The following is a description of a gene set: from publication Cui A, Huang T, Li S, Ma A, Pérez JL, Sander C, Keskin DB, Wu CJ, Fraenkel E, Hacohen N (PMID 38057668) Cytokines mediate cell-cell communication in the immune system and represent important therapeutic targets. A myriad of studies have highlighted their central role in immune function, yet we lack a global view of the cellular responses of each immune cell type to each cytokine. To address this gap, the authors created the Immune Dictionary, a compendium of single-cell transcriptomic profiles of more than 17 immune cell types in response to each of 86 cytokines (>1,400 cytokine-cell type combinations) in mouse lymph nodes in vivo. A cytokine-centric view of the dictionary revealed that most cytokines induce highly cell-type-specific responses. For example, the inflammatory cytokine interleukin-1β induces distinct gene programmes in almost every cell type. A cell-type-centric view of the dictionary identified more than 66 cytokine-driven cellular polarization states across immune cell types, including previously uncharacterized states such as an interleukin-18-induced polyfunctional natural killer cell state. Mouse Gene Set: CUI_T_CELL_CD8_IL18_RESPONSE_UP species: Mus musculus Genes positively differentially expressed in cell type: CD8+ T cell upon treatment with cytokine: IL-18 in mouse lymph nodes in vivo., and this is the list of marker genes: Dbnl, Psmb9, Ppa1, Npm1, Polr2f, Irf7, Hspd1, Psmd7, Cct4, Cct3, Bax, Zbp1, Tnfrsf9, Wdr12, Ptma, Rcc2, Pebp1, Ppp1r14b, Tcp1, Impdh2, Prmt1, Stip1, Sms, Iigp1, Eif2s1, Ifi35, Eif4a1, Nsun2, Mthfd2, Calhm6, Batf, Trp53, B2m, Banf1, Bzw2, Eif5a, Cd72, Eif6 (eukaryotic translation initiation factor 6), Icam1, H2-T22, Glrx5, Lyar, Shmt2, Cfdp1, Ssb, Phb1, Lad1, Rab8b, Nme1, Ly6a, Tpi1, Grap, Ssrp1, Pdcd5, Zmiz2, Apobec3, Gbp6, Eif3a, Pim2, Aprt, Serbp1, Srsf3, Cct2, C1qbp, Cd82, Relb, Atp5f1d, Rangrf, Edf1, Cdc37, Gbp2, Nudt5, Mrpl36, Irgm2, Mrpl20, Ly6e, Anp32b, Wars1, Hint1, Rrp9, Hspa4, Ier5, Psma5, Nip7, Samhd1, Pfdn6, Eif5b, Ptges3, Snrpf, Nolc1, Phb2, Txn2, Gbp8, Eif3g, Tapbpl, Jpt1, Rtp4, Pkm, Pfdn2, Uqcrq, Ppan, Sdhaf1, Ndufa12, Wdr43, Cks2, Mrpl12, Hnrnpd, Hsp90aa1, Cycs, Tomm40, Nop10, Cct5, Ruvbl1, Apex1, Ldha, Eef1g, Cyc1, Sumo2, Hspa8, Tap2, Lsm6, Ebna1bp2, Chchd1, Atp5f1b, Magoh, Cyba, Atad3a, Ddx21, Ppid, Gbp3, Ccdc86, Gar1, Eif1a, Hdgf, Fbl (fibrillarin), Phgdh, Bst2, Nop56, Dctpp1, Wdr18, Znrd2, Rars1, Npm3, Psmb10, Psma4, Srsf2, Cd83, Pgam1 (phosphoglycerate mutase 1), Fam162a, Glrx3, Utf1, Gadd45b, Isg15, Cct8, Tap1, Ifit3, Slc25a5, Vars1, Cd274, Psmb8 (NCBI Gene Id 16913), Hsp90ab1, Cdk4, Nop58, Psma2, Ncl, Lap3, Mettl1 (methyltransferase 1, tRNA methylguanosine), Mrpl15, Pomp, U2af1, St13, Tapbp, Eif1ax, Rsl1d1, Rbm3 (RNA binding motif (RNP1, RRM) protein 3), Rrp15, Mydgf, Pabpc4, Timm13, Pou2f2, Rrp1b, Cox5a, Sfxn1, Psme2, Sar1a (secretion associated Ras related GTPase 1A), Parp9, Odc1, Hnrnpab, Ms4a4c, Timm10, Stat3, Psmb6, Hspa5, Dkc1, Timm8a1, Nfkb1, Irf1, Mybbp1a, Gbp7, Mrto4, Tomm20, Llph, Cacybp, Psme1, Noc2l, Snu13, Tuba1b, Prdx1, Parp14, Pcbp1, G3bp1, Eif3c, Dtx3l, Atp5mc1, Ifi203, Rcl1, Irf8, Ndufab1, Rilpl2, Zfp593, Ybx3, Ftsj3, Eif3b (eukaryotic translation initiation factor 3, subunit B), Uchl3, Tkt, Gbp9, Ifrd2, Notch1, Park7, Mif, Ifng, Ndufaf4, Nhp2, Mrpl17, Rrs1, Gbp4, St6galnac4, Kdm2b, Srsf7, H2-K1, Psmc5, Ruvbl2, Polr2h, Galk1, Pdap1, Ybx1, Txn1, Ifi47, Gtpbp4, Set, Uqcc2, Snrpa1, Psmd6, Mat2a, Ssbp4, Psmb5, Cxcl10, Pa2g4, Ranbp1, Tuba4a, Psma6, Irgm1, Stat1, Nifk, Bcl3, Hspe1, Tma16, Psma7, Nudc, Srm, Strap, H2-T23, Psma3, Tufm, Igtp (NCBI Gene Id 16145), Eif2s2, Cops6, Ran, Cct7, Nfkbia, Tomm5, Ddx39a, Psmg4, Snrpd1, Eprs1, Nfkb2, Ndufb4, Socs1, Snrpb, Gnl3, Tmem238, Psmb2, Nop16, Lsm7, Taf10, Ifi27l2a (NCBI Gene Id 76933), Fkbp4, Mndal, Gbp5